The following is a description of a gene set: Cytokines mediate cell-cell communication in the immune system and represent important therapeutic targets. A myriad of studies have highlighted their central role in immune function, yet we lack a global view of the cellular responses of each immune cell type to each cytokine. To address this gap, the authors created the Immune Dictionary, a compendium of single-cell transcriptomic profiles of more than 17 immune cell types in response to each of 86 cytokines (>1,400 cytokine-cell type combinations) in mouse lymph nodes in vivo. A cytokine-centric view of the dictionary revealed that most cytokines induce highly cell-type-specific responses. For example, the inflammatory cytokine interleukin-1β induces distinct gene programmes in almost every cell type. A cell-type-centric view of the dictionary identified more than 66 cytokine-driven cellular polarization states across immune cell types, including previously uncharacterized states such as an interleukin-18-induced polyfunctional natural killer cell state. Mouse Gene Set: CUI_T_CELL_CD8_TL1A_RESPONSE_UP from publication Cui A, Huang T, Li S, Ma A, Pérez JL, Sander C, Keskin DB, Wu CJ, Fraenkel E, Hacohen N (PMID 38057668) species: Mus musculus Genes positively differentially expressed in cell type: CD8+ T cell upon treatment with cytokine: TL1A in mouse lymph nodes in vivo., and this is the list of marker genes: Icam1, Cyba, Stat1, Tapbp, Ikbke, H2-Q6, H2-Q4, Zmiz2, Sms, Cd82, Sdhaf1, Nfkb2, Ms4a4c, Birc3, Ptp4a2, Ltb, Ly6e, Kmt2a, Mndal, Relb, Gbp4, Grap, Psmb10, Nfkbia, Psme2, Cd83, Ier5, Apobec3, G3bp1, Traf1